The following is a description of a gene set: Human Gene Set: SMARCA1_TARGET_GENES studied in species Homo sapiens Genes containing one or more binding sites for (SMARCA1) in their promoter regions (TSS -1000,+100 bp) as identified by GTRD version 20.06 ChIP-seq harmonization. from publication Yevshin I, Sharipov R, Kolmykov S, Kondrakhin Y, Kolpakov F (PMID 30445619), and this is the list of marker genes: FGD6, NGDN, TACO1, STAT6, H2AC15, STX16, LRGUK, FAM66B, MAFB, TIMP2, ACSF3, RNY1P11, CASQ2, H4C2, KANSL1-AS1, SMAD2, KLHL12, RETREG2, SLC25A23, ADAP1, SNX29, MT-TR, UIMC1, PRKAA1, DEPDC1B (NCBI Gene Id 94594), DOP1B, IDH3A, COL3A1, WWP1P1, MT-ND4, ADAT2, MT-ND4L, RAD9B, SLC43A2, RHPN1, MIR4477A, TTC39A, PCDHB15, HSPE1, HSPD1, RPUSD1, SSX2IP (SSX family member 2 interacting protein), CUX1, SHARPIN, TOB2, PAX6, RFX1, H2AC21, PLGRKT, HERC5, TBX3, MED28-DT, MAP7, KANSL1, OR2A1-AS1, PPARD, STX16-NPEPL1, CHTF18, DDB1, LINC01596, MTCO3P12, VEZT, FOXN3, ZNF664, RNF121, HSPH1, TUBB4B, VPS29, P4HB, CYP4F11, EBLN3P, IQGAP2, TACC1, DNM2, ACADVL, VGLL4, MAP3K6, MIR638 (NCBI Gene Id 693223), DNAJB11, ERICH6, BSX, KLC2, H4C16 (NCBI Gene Id 121504), HSPE1-MOB4, DUSP14, H4C3, CNPPD1, ENSG00000227733, BMPR1A, RNF43, CCDC183-AS1, SOCS2, POU1F1, CITED2, N4BP3, FOXD3, STIP1, TMEM184B-AS1, NAALADL2, KLK2, ARID4A, CAPNS1, PEX3, COG1, MAP4K2, ARPC1B, VWA8-AS1, MT-ND5, H4C5, PSMA3-AS1, KLF11, ZNF252P, NUDT9 (nudix hydrolase 9), DIPK2A, CHASERR, ALG10B, EPHB4, H2BC15, TRIM21, YWHAZ, BOLA1, SMARCC1, ARMH4 (NCBI Gene Id 145407), ORC5, TMEM121, EHMT1, FEM1B, PHPT1, SNX14, TADA2A, TXNIP, MAF1, FOXD3-AS1, CD276, XNDC1N, ARRDC4, SLC41A2